Given this list of marker genes Tfrc (NCBI Gene Id 76361), Atp7b, Cdk1, Daxx, Cyp27b1, Prnp, Muc2, Bace1, Mt4, Snca, Aqp1, Aqp2, Nfe2l1, Map1lc3a, mt-Cytb, Mt1, Becn1, Sod3, Hsf1, Loxl2, Park7, Sod1, mt-Co1, Il1a, Cyp1a1, Mt3, Mt2, Atp7a, Nfe2l2, Sord, Cp, Lcat, Aanat, here is a description of the gene set: species: Mus musculus Mouse Gene Set: GOBP_RESPONSE_TO_COPPER_ION Any process that results in a change in state or activity of a cell or an organism (in terms of movement, secretion, enzyme production, gene expression, etc.) as a result of a copper ion stimulus.